The following is a description of a gene set: from publication Huang Z, Dore LC, Li Z, Orkin SH, Feng G, Lin S, Crispino JD (PMID 19620289) Mouse Gene Set: HUANG_GATA2_TARGETS_DN studied in species Mus musculus GATA-2 is an essential transcription factor that regulates multiple aspects of hematopoiesis. Dysregulation of GATA-2 is a hallmark of acute megakaryoblastic leukemia in children with Down syndrome, a malignancy that is defined by the combination of trisomy 21 and a GATA1 mutation. Here, we show that GATA-2 is required for normal megakaryocyte development as well as aberrant megakaryopoiesis in Gata1 mutant cells. Furthermore, we demonstrate that GATA-2 indirectly controls cell cycle progression in GATA-1-deficient megakaryocytes. Genome-wide microarray analysis and chromatin immunoprecipitation studies revealed that GATA-2 regulates a wide set of genes, including cell cycle regulators and megakaryocyte-specific genes. Surprisingly, GATA-2 also negatively regulates the expression of crucial myeloid transcription factors, such as Sfpi1 and Cebpa. In the absence of GATA-1, GATA-2 prevents induction of a latent myeloid gene expression program. Thus, GATA-2 contributes to cell cycle progression and the maintenance of megakaryocyte identity of GATA-1-deficient cells, including GATA-1s-expressing fetal megakaryocyte progenitors. Moreover, our data reveal that overexpression of GATA-2 facilitates aberrant megakaryopoiesis. Genes down-regulated in G1ME cells (megakaryocyte/erythroid progenitor lacking GATA1) upon knockdown of GATA2 by RNAi., and this is the list of marker genes: Fdps, Gbx2, Trmt61a, Shmt2, Clu, Aurka, Pbx1, Nomo1, Nup107, Slc2a1, E2f2, Mthfd2, Dctd (dCMP deaminase), Mthfd1l, Irag1, Tmem132a, Asns (NCBI Gene Id 27053), Lat, Pf4, Pigt, Chac1 (NCBI Gene Id 69065), Ctps1, Gpat4, Egr1, Fam3c, Slc6a9, Daam1, Znrd2, Rcor1, Txndc5, Parm1, Nt5c3, Gucy1a1, Tmem109 (transmembrane protein 109), Diaph3, Lmo2, Pdcd4, Zfpm1, Exoc3l4, Skp2, Klf1 (Kruppel-like transcription factor 1 (erythroid)), Pramel37 (NCBI Gene Id 381724), Arhgap29, Plagl2, Nsf, Ackr1, Golt1b (golgi transport 1B), Tfrc, Phlda1, Gata2, Scd1, Slamf1, Hk2, Pdgfb, Ippk, Siah1b, Slc1a4, St3gal6, Gp1bb, Ipo11, Tcof1, Tacc1, Jmjd6, Fhl1, Mrpl38, Arf2, Actb, Eif3d, Etf1, Sema4b, Podxl, Rrp1b, Rabgef1, Slc2a3 (NCBI Gene Id 57873), Pfas